The following is a description of a gene set: Increased volume of the earlobe, that is, abnormally prominent ear lobules. studied in species Homo sapiens Human Gene Set: HP_LARGE_EARLOBE Large earlobe, and this is the list of marker genes: BICRA, PHF6, PIGY, CNTNAP2, ZEB2, TMEM94, HRAS, TRIP12, EIF2S3, SMOC1 (NCBI Gene Id 64093), UFC1, SPEN, FGD1, UGDH, PGAP3, DHCR24, EFTUD2, MLXIPL, VPS53, WDR4, PHIP, GJA1, ZFX, SLC26A2, KMT2D, CDH11 (NCBI Gene Id 1009), DPYD, PLXNA1, NOTCH2, DOCK7, PIK3CA, TPRKB, ELN, PGM2L1, OTUD5, BRAF, KDM6A (lysine demethylase 6A), WARS1, SETBP1